The following is a description of a gene set: Catalysis of the reaction: NADP+ + testosterone = NADPH + H+ + androst-4-ene-3,17-dione. Mouse Gene Set: GOMF_TESTOSTERONE_17_BETA_DEHYDROGENASE_NADPPLUS_ACTIVITY species: Mus musculus, and this is the list of marker genes: Hsd17b3 (hydroxysteroid (17-beta) dehydrogenase 3), Akr1c6, Akr1c20, Hsd17b14, Hsd17b6, Dhrs1, Hsd17b1